The following is a description of a gene set: part of: Interferon Signaling studied in species Mus musculus This event has been computationally inferred from an event that has been demonstrated in another species.<p>The inference is based on the homology mapping from PANTHER. Briefly, reactions for which all involved PhysicalEntities (in input, output and catalyst) have a mapped orthologue/paralogue (for complexes at least 75% of components must have a mapping) are inferred to the other species. electronically inferred by orthology from the curated human pathway Reactome Pathway: Modulation of host responses by IFN-stimulated genes, and this is the list of marker genes: Arih1, Ikbkb, Uba7, Rigi, Ifi44